Given this list of marker genes TMPRSS4, KRT6A, EXOC2, TRIM5, TRIM25, CD74, LGALS9, CH25H (cholesterol 25-hydroxylase), CXCL8, ITGAV, TMPRSS2, NECTIN2, EXOC7 (NCBI Gene Id 23265), TRIM11, TRIM38, CAV1, TRIM21, LGALS1, FUCA2, HMGB1, CD4, HLA-DRB1, HS3ST5, P4HB, SMPD1, FURIN, TRIM62, BSG, here is a description of the gene set: Any process in which an organism modulates the frequency, rate or extent to which it enters into the host organism, where the two organisms are in a symbiotic interaction. species: Homo sapiens Human Gene Set: GOBP_MODULATION_BY_SYMBIONT_OF_ENTRY_INTO_HOST